Given this list of marker genes MPO, ELANE, IL3, CSF2, DEFA3, NCOR1, HDAC2, RUNX1, GZMB, HDAC1, SIN3A, here is a description of the gene set: Pathway Definition from KEGG: TEL-AML1 == (HDAC+SIN3A+NCOR1) =| (IL3,CSF2,MPO,DEFA3,ELANE,GZMB) TEL-AML1 fusion to transcriptional repression. Pathway ID: N00118. Pathway type: Variant. Pathway class: nt06240 Transcription. Human Gene Set: KEGG_MEDICUS_VARIANT_TEL_AML1_FUSION_TO_TRANSCRIPTIONAL_REPRESSION studied in species Homo sapiens